The following is a description of a gene set: Binding to a basic Helix-Loop-Helix (bHLH) superfamily of transcription factors, important regulatory components in transcriptional networks of many developmental pathways. studied in species Homo sapiens Human Gene Set: GOMF_BHLH_TRANSCRIPTION_FACTOR_BINDING, and this is the list of marker genes: CREBBP, IKZF4, FIGLA, TWIST1, TCF15, NCAPG2, KDM1A, SCX, TCF12, KLF5, ASCL2, PSMD9, ASCL1, HAND1, FHL2, MAP3K10, ID3, SIRT1, BHLHE40, USF1, BHLHE41, LMO2, SOX9, USF2, SP1, TCF3, FOXH1, RUNX2, SMAD3, MYOD1, TCF21, ISL1